Given this list of marker genes Zdhhc14, Col6a2, Thy1, Pcmtd2, Atp8a1, Cnga2, Cav1, Ramp1, Col9a3, Itga7, Mxd4, Dcaf12l1, Timp3, Zfp36, Itga5 (integrin alpha 5 (fibronectin receptor alpha)), Emp1, Syn2, Dzip1, Pvalb, Fosl2, Lpar1, Plagl1, Cspg4, Clu, Trim30a, Tst, Fndc3c1, Draxin, Cryab, Col4a1, Mertk, Bcl2l11, Fosb, Emilin1, Ephb1, Arvcf, Rhou, Serpinh1, Ddhd1, Kcna6, Efs, Sorl1, A830073O21Rik, Ccn1, Ptgds, Pcolce2, Pdlim4, Slc26a2, Tsc22d1, Prkcq, Ndrg2, Rnase1, Padi2, Mapt, Cd109, Nisch, Cadps, Psd2, Pgm5, Ppfibp2, Rdh5, Lsamp, here is a description of the gene set: The glioblastoma multiforme (GBM) plasticity signature: genes down-regulated in neural stem cells (NSC) with double knockout of TP53 and PTEN vs those with knockout of TP53 alone. Glioblastoma (GBM) is a highly lethal brain tumour presenting as one of two subtypes with distinct clinical histories and molecular profiles. The primary GBM subtype presents acutely as a high-grade disease that typically harbours mutations in EGFR, PTEN and INK4A/ARF (also known as CDKN2A), and the secondary GBM subtype evolves from the slow progression of a low-grade disease that classically possesses PDGF and TP53 events. Here we show that concomitant central nervous system (CNS)-specific deletion of p53 and Pten in the mouse CNS generates a penetrant acute-onset high-grade malignant glioma phenotype with notable clinical, pathological and molecular resemblance to primary GBM in humans. This genetic observation prompted TP53 and PTEN mutational analysis in human primary GBM, demonstrating unexpectedly frequent inactivating mutations of TP53 as well as the expected PTEN mutations. Integrated transcriptomic profiling, in silico promoter analysis and functional studies of murine neural stem cells (NSCs) established that dual, but not singular, inactivation of p53 and Pten promotes an undifferentiated state with high renewal potential and drives increased Myc protein levels and its associated signature. Functional studies validated increased Myc activity as a potent contributor to the impaired differentiation and enhanced renewal of NSCs doubly null for p53 and Pten (p53(-/-) Pten(-/-)) as well as tumour neurospheres (TNSs) derived from this model. Myc also serves to maintain robust tumorigenic potential of p53(-/-) Pten(-/-) TNSs. These murine modelling studies, together with confirmatory transcriptomic/promoter studies in human primary GBM, validate a pathogenetic role of a common tumour suppressor mutation profile in human primary GBM and establish Myc as an important target for cooperative actions of p53 and Pten in the regulation of normal and malignant stem/progenitor cell differentiation, self-renewal and tumorigenic potential. species: Mus musculus Mouse Gene Set: ZHENG_GLIOBLASTOMA_PLASTICITY_DN from publication Zheng H, Ying H, Yan H, Kimmelman AC, Hiller DJ, Chen AJ, Perry SR, Tonon G, Chu GC, Ding Z, Stommel JM, Dunn KL, Wiedemeyer R, You MJ, Brennan C, Wang YA, Ligon KL, Wong WH, Chin L, DePinho RA (PMID 18948956)